The following is a description of a gene set: Catalysis of the removal of a methyl group from a substrate. species: Homo sapiens Human Gene Set: GOMF_DEMETHYLASE_ACTIVITY, and this is the list of marker genes: KDM4C (NCBI Gene Id 23081), KDM2B, RIOX2, RIOX1, KDM4E, RSBN1, KDM3B, KDM4A, KDM6A, KDM6B, ALKBH4, JARID2, KDM1B, KDM3A, UTY, KDM2A, KDM5B, ALKBH5, MMACHC, KDM7A, CYP1A1, ALKBH3 (alkB homolog 3, alpha-ketoglutarate dependent dioxygenase), JMJD6, KDM4F, KDM5A, KDM8, ALKBH2, JMJD1C, FBXL19, KDM5D, CYP51A1, HR, FTO, PHF2, KDM4D, ALKBH1, CYP1A2, KDM4B, KDM1A, PHF8 (PHD finger protein 8), KDM5C